Given this list of marker genes Adarb1, D1Pas1 (NCBI Gene Id 98517), Pkn2, Tarbp2, Top2a, Trim38 (NCBI Gene Id 214158), Ppid, Vapb, Adar, Nr5a2, Stau1, Srpk2, Gbp7, Hacd3, Tmem39a, Notch1, Cnot7, Ppie, Ppia (peptidylprolyl isomerase A), Larp1, Srpk1, Ddx3x, Pde12, Rad23a, Ppihl, Ddb1, Ppih, Fkbp6, Top2b, here is a description of the gene set: Mouse Gene Set: GOBP_POSITIVE_REGULATION_OF_VIRAL_GENOME_REPLICATION studied in species Mus musculus Any process that activates or increases the frequency, rate or extent of viral genome replication.